Given this list of marker genes APEX1, SLFN12, ATF6, FCGR2A, SNAP23, TRIP11, SOX5, MDH2, SH3GL3, TCFL5, NLRP3, PON3, SBNO2, FLOT1, CD38, RIOX1, AKIRIN1, TRIO, LITAF, MCOLN2, VKORC1L1, TUBB2A, NRP2, TENT5C, VAMP7, TG, ALDH2, VMP1, CTSZ, ADK, EIF2S2, CELSR1, TGM2, RBM47, LPXN, AUH, FIG4, OTULIN (OTU deubiquitinase with linear linkage specificity), CA13, UBXN7, ERP44, BCO2, NABP1, PTGER4, VWA5A, CSF2RB, G0S2, MMGT1, ADPGK, FGL2, PFKFB3, ATXN1, ST3GAL1, TMEM154, SLC41A1, SOS1, ARG2, CHRNB1, ID2, ZDHHC6, SNX10, ANKRD33B, RILPL1, ZC3H12D, PPA1, YAF2, GNL3, IRF9 (interferon regulatory factor 9), EIF2S1, LIFR, SUB1, NOP58, PIM1, TMED5, ACBD5, SLC31A1, FAH, PIK3IP1, POU2AF1, SCAMP1, PTGS2, ELOC, RAB31, CD9, FUCA2, NINL (ninein like), TBC1D9, GAB2, HDC, CYTIP, PSMD14, CRIP1, CD80, TIMM8A, CLVS1, ECHDC3, C5AR1, CHD1, PYGO1, CLTC, BCAP29, TIPARP, NFIL3, RAB6A, GBP2, ADGRL2, NIPA2, CASS4, PSTPIP2, RIPK1 (receptor interacting serine/threonine kinase 1), IL1RN, COQ10B, EMILIN2, AGPAT4, PRDM1, KRT222, AZIN1, SLC38A2, DUSP1 (NCBI Gene Id 1843), UBE2G1, SPECC1, CHST11, STIM2, RILPL2, SIRPA, CTLA4, ABHD17B, SSPN, RAP1A, OOSP2, CAMK2D, RC3H2, TMEM176B, CCDC28B, EIF2S3, PDCD1LG2, NR3C2, VIM, FCHO2, BCL3, CSF1, B4GALT1, FLVCR1, ZNF281, IL1B, IL6ST, TNFAIP2, DTX3L, STX7, PRKCG, FXYD5, S100A10, RESF1, GEM, EMC7, CDH17, TPD52, HIPK3, CD300LD, AHR, TTC33, AGO3, PRPS1, MTSS1, IL1R2, GRINA, MAN2A2, PRDX1, STK38, CXCL3 (C-X-C motif chemokine ligand 3), TMEM167A, JUN, FCGR2B, DUSP3, HMGN3, PLEKHA3, AFDN, ANXA2, OPA3, CD68, NUDCD2, CD5, CLEC4D, RASSF4, PLAC8 (placenta associated 8), PTPN1, YWHAQ, ACTN1, FOSL2, GAS7, CLEC4E, PEPD (peptidase D), PGS1, LAMP2, RNPS1, PDE8A, MRPL45, CCR5, PTPN12, TAF4B, here is a description of the gene set: from publication Yang XD, Ai W, Asfaha S, Bhagat G, Friedman RA, Jin G, Park H, Shykind B, Diacovo TG, Falus A, Wang TC (PMID 21170045) Differentially expressed genes of CD11b+Gr-1+ immature myeloid cells (IMCs) in the bone marrow and colonic tumor setting of histidine decarboxylase (HDC)-KO mice were examined by microarray (Affymetrix Mouse 430.2 array). Myeloid differentiation-related candidate genes were sought to be isolated and functionally studied. Human Gene Set: GSE23502_WT_VS_HDC_KO_MYELOID_DERIVED_SUPPRESSOR_CELL_BM_DN studied in species Homo sapiens Genes down-regulated in myeloid-derived suppressor cells from bone marrow: wildtype versus HDC knockout.